Given this list of marker genes DNM2 (dynamin 2), SHOX, ASH1L, TMEM63C, DDRGK1, MFN2, POMT1, RMRP, PRG4, BGN (biglycan), PRKG2, GFPT1, GNPNAT1, COL12A1, SON, TOGARAM1, SATB2, MYBPC1, CHST3, NSDHL, RERE, TRAPPC2, MED12, COL10A1, EBF3, TPM3, ITCH (itchy E3 ubiquitin protein ligase), GARS1, ALG14, BCOR, FKRP, RAB3GAP2 (RAB3 GTPase activating non-catalytic protein subunit 2), EXTL3, IHH, GSC, FGFR3, XYLT1, FN1, HERC1, VAC14, COL2A1, ADAMTS10 (NCBI Gene Id 81794), OBSL1, CHST11, MYH7, SOX5, SMAD4, VPS13B, PCGF2, KY, DPAGT1, AP1G1, POLR3GL, MTMR14, ALG2, SETBP1, NPR2, ALX3, NAA10, COL6A1, HACE1, ABCC9, FUCA1, DAG1, ACAN, COL6A2, HSPG2, LIPE (NCBI Gene Id 3991), TAF4, LTBP1, SLC26A2, AHDC1, SMARCAL1, TPM2, FBN1, DMD (dystrophin), SYT1, CFL2, SGCG (sarcoglycan gamma), RYR1, COL27A1, PLEC (NCBI Gene Id 5339), COMP, LMX1B, COL11A2, PIEZO2, POMT2, VCP, DYM, VPS33A, ACP5, POMK, ARSB, COL6A3, TRPV4, TONSL, POMGNT1, MATN3, MYPN, CLCF1, GMPPB, here is a description of the gene set: Lumbar hyperlordosis An abnormal accentuation of the inward curvature of the spine in the lumbar region. species: Homo sapiens Human Gene Set: HP_LUMBAR_HYPERLORDOSIS